The following is a description of a gene set: studied in species Homo sapiens Human Gene Set: chr6p12, and this is the list of marker genes: LRRC1, GCLC, RPSAP44, TFAP2B, SOD1P1, GSTA6P, FTH1P5, ADGRF5, ENSG00000287485, GSTA11P, MIR206, RCAN2 (NCBI Gene Id 221402), CRISP2, PKHD1, RNU6-1023P (RNA, U6 small nuclear 1023, pseudogene), FAM83B, FBXO9, ELOVL5, RPA3P2 (NCBI Gene Id 100130403), GSTA1, GSTA12P, GSTA3, TINAG, PTCHD4, GSTA4, RPL10P10, TFAP2D, HMGB1P20, RNU1-105P, TMEM14A, ENSG00000300363, COL21A1, BMP5, RN7SL580P, BEND6, DEFB114, KIAA1586, RPS16P5, DST, HMGCLL1, HCRTR2, CILK1, TDRD6-AS1, GFRAL, CENPQ, KLHL31, RPL36P10, ENSG00000307590, DEFB110, TRAM2, EFHC1, DHFRP6, RNU7-65P, RCC2P7, MRPL30P1, TRAM2-AS1, C6orf141, OSTCP6, CD2AP, GLYATL3, GSTA2, BAG2, KILH, ENSG00000227885, GSTA10P, MLIP-AS1, ZNF451, ENSG00000288614, OPN5, TINAG-AS1, RHAG, RPL27AP7, MTMR9P1, RPS15AP20, PLA2G7, RN7SK, RPL31P33, MMUT (NCBI Gene Id 4594), PAQR8, ZNF451-AS1, MLIP, CRISP1, PGK2, ENSG00000212532, GCM1, LINC01564, RN7SKP256, RNU1-136P, KRASP1, ADGRF2P, DEFB133, ADGRF4, TDRD6, EEF1A1P42, TIAL1P1, GSTA8P, MIR133B, IL17A, ADGRF5-AS1, GSTA9P, CLNS1AP1, GSTA7P, IL17F, RPL17P26, DST-AS1, RBMXP1, ERHP2 (NCBI Gene Id 100874403), CYP39A1, RPS12P14, ANKRD66, TNPO3P2, ACTG1P9, RNU6-464P, SLC25A20P1, MEP1A (meprin A subunit alpha), RN7SKP116, ADGRF1, SREK1IP1P2, RNU6-626P, CRISP3, SLC25A27, ENSG00000288646, NANOGP3, ENSG00000291006, RPL31P28, CYP2AC1P, WTAPP2, RPS17P5, CD2AP-DT, PRR11P1, RCAN2-DT, FTH1P15, GSTA5, GCLC-AS1, MCM3, HNRNPA3P4, MIR5685, RN7SL244P, B3GNTL1P2, LINCMD1, TNFRSF21, NPM1P36, DEFB113, DEFB112